The following is a description of a gene set: Genes in the cancer module 202. studied in species Homo sapiens Human Gene Set: MODULE_202, and this is the list of marker genes: SORBS2, FLNA, PFN2, ACTN4 (NCBI Gene Id 81), ANK1, MYL3, MYH11, SVIL, NEBL, MYBPC2, DSTN, LSP1, MYBPC1, NEB, TNNT3, MYBPH, FLNB, ACTA2, MYL11, MYH7, MYH3, MYOM1, MYOM2, GSN, MYL6, MYL1, PPP1R12A, ABLIM1